The following is a description of a gene set: studied in species Homo sapiens from publication Chen Y, Wang X (PMID 31504780) Human Gene Set: MIR149_3P Genes predicted to be targets of miRBase v22 microRNA hsa-miR-149-3p in miRDB v6.0 with MirTarget v4 prediction scores > 80 (high confidence targets)., and this is the list of marker genes: CNGA2, ARFRP1, SV2A, C1RL, SERPINA1, PLA2G4E, IRGQ, PLAGL2, ABO, KCNQ4, VAMP2, PRR30, DNAJB2, SDK1, USP37, ADAM21, RPRD2, PACSIN1, PNMA2, RFT1, SYNGR1, CDKN1A, RPS6KA2, RAP1GAP2, ADAM12, NAV2, RHO, NGFR, THY1, PSMB2, ZSCAN30, HMGXB3, BCL9, ZNF667, MTA2, STX2, SUSD6, CASP10, FBXO10, NFIX, IQSEC1, ZNF544, TMTC1, STXBP1, DES, MTCL2, MYRF, HOXB8, RUSC1, MAP3K9, KCNQ2, GLDN, CALN1, GRSF1, STIM1, RNF222, SUPT5H, PARVG, PLA2G2A, N4BP1, MECP2, EYA3, SOX12, NYNRIN (NCBI Gene Id 80151), PLEKHA5, CBLN3, XYLT1, ADGRL1, AGPAT1, SLITRK5, DPF3, MAFF, NTSR1, GALNT2, C1orf210, CSF1, ATF7, CLIP2 (CAP-Gly domain containing linker protein 2), SYN2, ATXN1, PTK2, PTPRA, C2CD2L, NDST1, SCAMP4, THTPA, NOVA2, RELT, CDC23, AR (NCBI Gene Id 367), LZTS3, TMEM252, ZNF710, METTL21A, TLNRD1, XKR6, NIBAN2, HCFC1, APRG1, SLC12A4, SMG6, SENP5, PPP1R9B, PPARD, PARP11, SH3GL1, TNS1, VSIG10L, MRPL43, LENG8, DUSP8, SLC35F6, SLC25A23, CCDC69, SLC4A8, ZBTB4 (NCBI Gene Id 57659), ABHD14B, FLT4, KIAA1549, DUSP4, MXD3, TMEM63C, LRP1, ARNT2, APLNR, NOX1, ABCB8, MKNK2, ASIC1 (acid sensing ion channel subunit 1), ZNF385A, LYN, DACT1, PHYHIP, RTN3, NOS1, PIK3R2, AHDC1, CAMK1 (NCBI Gene Id 8536), POU2AF1, MEF2D, TRIM67, ELK1, ADCYAP1R1, WNT9B, SCN4B, KLC2, VPS37C, PLXNA4, PPM1F, MLLT6, VSIR, PA2G4, ANKRD45, SAMD10, MMP19, BICDL1, EDNRA, TMEM184B, KIF21B, ENTPD2, MAVS, PRICKLE1, GRK2, RSPO4, KCTD10, PRG4, NRSN2, FANCF, POLR2E, CSDE1, CREB3L2, TTYH3, S100A5, GSK3A, SORCS1, ERF, TMEM104, PURA, MINK1, ACP3, UNC5B, BSN, KRT75, SLC6A11, SARM1, TBC1D24, B9D1, MGRN1, SOX13, CSMD2 (NCBI Gene Id 282565), SYNGAP1, NFIC, RIMS3, PCBD1, G6PC3, ERI3, FOXK1, C9orf78, CBX6, DNM1, FURIN, FGFR1OP2, NUTM2G, NLGN3, SBF1, PPP5D1P, CTSD, SUFU, SSBP3, IL2RG, OAF, TFAP2B, TMEM276, CYP26B1, POMT2, NECTIN1, SMARCD1, SHISA6, MPDU1-AS1, CASKIN1, WDTC1, PNPO, RPL15, GANAB, GFOD2, RNF24 (ring finger protein 24), MTFMT, TRAPPC14, NFASC, TMEM120B, PRR12, AP1S1, BCL2L1, POLR1G, MYO1C, HOXA10, NHERF2, HOXC4, TSPAN18, PBX2, MNT, PTPRJ, UTP11, PNPLA2, PAPOLG, NR1D1, ARPC2, PITPNM3, STX1A, CAPZB, RAVER1, STK35, SRRM4, TMEM164, CNP, PKNOX2, COL5A3, SEC22B, MTF1, RALB, ELFN2, MYH14 (myosin heavy chain 14), YPEL4, PACS1, DDX18, RAB3IL1, NPTXR, CCDC180, FSCN1, BET1L, YBX2 (NCBI Gene Id 51087), YWHAQ, MGAT5B, ATXN2L, KHSRP, ABCG4, PTMS, PIGR, CDR2L, IFFO2, PDE7A, HK1, MDM4, DISP3 (dispatched RND transporter family member 3), PEX2 (peroxisomal biogenesis factor 2), MIEF2, CPQ, ZNF384, APCDD1, MEAK7 (MTOR associated protein, eak-7 homolog), GNAT1, DDAH1, RNF44, CSF2RB, ARHGEF11 (NCBI Gene Id 9826), TIMP3, IQSEC3, ZCCHC3, AVPR2 (NCBI Gene Id 554), RAB11B, CERCAM, FAM131C, ELAVL3, SYNJ1, FIBCD1, MPP2, SYT7 (NCBI Gene Id 9066), KIF18B, ZNF518B, RALGDS, RAD51B, SLC2A4, ATP8A2, INKA2, SH3BP2, TPCN1 (NCBI Gene Id 56236), GLP1R, CARM1, COL11A2, ANKRD52, C20orf96, TUBB4A, MAPT, FOXP4, RPL32, NUP98, PIK3C2B, KCNK15, CSDC2, BAZ2B, DAGLA, ALX4 (NCBI Gene Id 64068), CASTOR2, FNIP1 (folliculin interacting protein 1), DTX4, F11R, PRKACA, CORO2B, GNAO1, DEPDC5, TAF4, PRR32, FAIM2, KCNIP1, DESI1, DAB2IP, RAB5B, SLC22A23 (NCBI Gene Id 63027), PXDC1, APOA5, FAM131B (NCBI Gene Id 9715), KCND3, NCOR2, TAP1, TOMM40, KIF1A, NPTX1, MYO10 (myosin X), IKZF3, PAIP2B, KSR2, SV2C, AP2A1, RBFOX2, SCRT1, ARPC4-TTLL3, PITPNM2, CIC, CDC42BPA, CHST3, RPH3AL, SDC3, ABCB5, AGAP1, ZFAND5, EIF4EBP2, RHOC (ras homolog family member C), RAB37, SLC22A11, RNMT, IGSF8, TGFBR3L, POU2F2, COL6A1, GGCX, RRP15, BAZ2A, DLGAP4, SAV1, TSKU, RNF38, PRKCA, CNNM1, CCDC43, RBMS2, SLC8A2, PDLIM2, LRRC4B, KRTAP4-11, HIPK2, MVB12B, ORAI2, GPM6B, NACC1, KIF5A, TET3, DLK1, SREBF2, VWA5B2, SHISA7, PPM1J, HYI, POLH, COPS7B, MDC1, SLC7A1, AGAP2, CYP1A2, ALPL, MORC4, RAB35, RASSF5, FAT2, RBM24, SYT15, SPRY4, PLCXD1, ATP2A3, MEX3A, ALPG, ELAVL1, ARHGAP23, STARD9, ACKR2, ARHGDIA